The following is a description of a gene set: Any process that activates or increases the frequency, rate, or extent of an immune effector process. Human Gene Set: GOBP_POSITIVE_REGULATION_OF_IMMUNE_EFFECTOR_PROCESS species: Homo sapiens, and this is the list of marker genes: GPI, FOXP3, ITGB2, FCN2, CD226, KIT, KLK3, SHLD1, PHB1, ULBP3, CD74, DDX1, BCL10 (BCL10 immune signaling adaptor), CFP, HPX, EXOSC3, MAVS, PTPRC, ADORA2B, IL18R1, ZP3, SLAMF6, CD55, CD36, ARG1 (arginase 1), DENND1B, TRIM6, SPI1, KLK7, IL1R1, TRAF2, DDRGK1, FCER1G, MZB1, PVR, VAMP8, KLRC3, LAMP1, TNFSF13, MBL2, APPL2, CD1C, SIRT1, CRTAM, SHLD3, VAMP3, HLA-F, IL1B, NR4A3, FGR, HLA-B, NSD2, PHB2, ANKRD17, TLR7, PANX1, FADD, KLRC2, GATA1, EXOSC6, PTPN6, CD1B, ENPP3, HK1, STAP1, IL6, XCL1, RARA, STX4 (NCBI Gene Id 6810), KLRC4-KLRK1, IL18, C17orf99, IL2RG, SASH3, CARD9, RASGRP1, INAVA, CLEC7A, IL12RB1, LTA (lymphotoxin alpha), EPHB2, DDX21, CCL19, GPR65, SNX4, MSH2, IL5, PAXIP1, HLA-E, TGFB1, B2M, CD28, IL23R, VAMP7, TNF, RIF1, MYD88, CCR2, HLA-DRB1, HLA-H, IRF5, FER, XBP1, DDX60, IL17F, ARID5A, WNT5A, RBP4, MIR520E, STX7, KIR2DL4, CD244, TP53BP1, ANXA1, ULBP1, PMS2, HLA-A, IL12A, IL12B, NOD2, NLRP3, SHB, NOD1, SHLD2, LACC1, ULBP2, KMT5C, RASGRP4, CYRIB, CAMK4, IFNG, TREM2 (NCBI Gene Id 54209), BTK, IL33, P2RX7, IL18RAP, CLNK, HLA-DRA, TAP2, MAPKAPK2, RAET1G, AZGP1, DEFB131A, COLEC11, MIR520B, F2RL1, GALNT2 (NCBI Gene Id 2590), RTN4, PLA2G5, TYROBP, DNAJB9, GPRC5B, RPS19, BRD4, KLHL22, VAV1, TLR9, C3 (NCBI Gene Id 12266), SOCS5, MAD2L2, SPON2, IL4R, RSAD2, TNFRSF4, TFRC, KLRD1, HLA-G, CLCF1, PRKCZ, COLEC10, AP1G1, KMT5B, PYCARD, NFKBID, CD81 (CD81 molecule), MIR21, IL23A, LBP, GAB2, RIPK2 (receptor interacting serine/threonine kinase 2), TBX21, FBXO38, MAP3K7, TNFSF4, STXBP1, STAT5A, GATA2, CD37, DHX58, LGALS9, PGC, HMCES, SECTM1, FFAR3, NFKBIZ, ATAD5, CD7, LAG3, TLR3, HSPD1, FCGR1A, CD40, CADM1, FCN1, SLC7A5, IL10, GATA3 (GATA binding protein 3), EP300, SLC22A13, SEMA7A, BRD2, CD80, MLH1, RIGI, SLAMF1, CR1, DHX36, KLRC4, TICAM1, FFAR2, TLR4, CD300A, MYO18A, CD177, CD1D, IL2 (interleukin 2), PRKAA1, SH2D1A, SYK, LAPTM5, CD86, NCR3, CD1E, ZBTB1, TRAF6, RAET1L, HLA-C, FCER2, STAT6, STAT5B, SCIMP, IL21, HLA-DMB, IL4, LILRB1, IL13, MALT1, NECTIN2, YWHAG, NOS2, HLX, KLRK1, PLCG2, TNFRSF14, SH2D1B, KLK5, IL17A, ITGAM, HLA-DRB3, USP17L2, FCN3, POMC, PLA2G3, HTR2A, SPHK2, CD160, OPA1, CD46, CD1A, IL13RA1, MR1, RAET1E, FZD5, KLRC1, PCK1, MIF